Given this list of marker genes Lig1, Rfc1, Rfc3, Pold2, Pold4, Pole, Pole2, Adprs, Apex1, Pcna, Rpa1, Pold1, here is a description of the gene set: electronically inferred by orthology from the curated human pathway part of: Resolution of Abasic Sites (AP sites) Reactome Pathway: Resolution of AP sites via the multiple-nucleotide patch replacement pathway This event has been computationally inferred from an event that has been demonstrated in another species.<p>The inference is based on the homology mapping from PANTHER. Briefly, reactions for which all involved PhysicalEntities (in input, output and catalyst) have a mapped orthologue/paralogue (for complexes at least 75% of components must have a mapping) are inferred to the other species. species: Mus musculus